The following is a description of a gene set: part of: Signaling by MET species: Homo sapiens Reactome Pathway: MET activates PTPN11 PTPN11 (SHP2), recruited to activated MET receptor through GAB1, is phosphorylated in response to HGF treatment, although phosphorylation sites and direct MET involvement have not been examined. Phosphorylation of PTPN11 in response to HGF treatment is required for the recruitment and activation of sphingosine kinase SPHK1, which may play a role in HGF-induced cell scattering. While PTPN11 promotes MAPK3/1 (ERK1/2) signaling downstream of MET, it can also dephosphorylate MET on unidentified tyrosine residues., and this is the list of marker genes: GRB2 (NCBI Gene Id 80715), GAB1, MET, PTPN11, HGF